Given this list of marker genes SYNE2, DAB2IP, SUN1, SRGAP2, SRGAP2C, BMERB1, SUN2, here is a description of the gene set: The movement of a cell along the process of a radial glial cell involved in cerebral cortex glial-mediated radial migration. Human Gene Set: GOBP_CELL_MOTILITY_INVOLVED_IN_CEREBRAL_CORTEX_RADIAL_GLIA_GUIDED_MIGRATION species: Homo sapiens